The following is a description of a gene set: species: Homo sapiens In this final phase of mitosis, new membranes are formed around two sets of chromatids and two daughter cells are formed. The chromosomes and the spindle fibers disperse, and the fiber ring around the center of the cell, composed of actin, contracts, pinching the cell into two daughter cells. part of: M Phase Reactome Pathway: Mitotic Telophase/Cytokinesis, and this is the list of marker genes: PDS5A, SMC3, KIF23, MAU2, STAG2, NIPBL, WAPL, KIF20A, SMC1A, PDS5B, PLK1, STAG1, RAD21